The following is a description of a gene set: Genes in the cancer module 248. species: Homo sapiens Human Gene Set: MODULE_248, and this is the list of marker genes: SHB, USH2A, GRB10, TULP1, DGKE, HRH1, GUCY1A2, CASK, FGR, GNAT2, CRYGD, PTPN6, PTPN13, CRYM, PDLIM4 (NCBI Gene Id 8572), STAT4, SOCS3, RIN1, PRKCA, RASA3, ARAF, CNGA3, CXCL8, CXCL1, PITPNA, IMPG1, TULP2, HTRA1, ITK, LIN7A, PLCG1, SH2B2, APBA1, MPDZ, PHYH, RS1, MYOC, PRPH2, BCAR3, DLG3, EML2 (EMAP like 2), FBN1, LCK (NCBI Gene Id 95387), PTPN3, CYP1B1, GRK1, PDCL, ABL2, PRB4, TXK (TXK tyrosine kinase), CRYGA, PRKCQ, CXCR2, CRYAB, KRT12, RRH, SOCS1, PDE6B, BEST1, DGKA, PAX2, NPR2, BCR, PSEN2, PDE6A, PRKCG, STMN2, PRKD1, RCVRN, EML1, ARHGEF11, PTPN11, JAK1, WFS1, ADCY8, GRAP2, CYTIP, GUCY2D, S100A1, PRKCZ, CHN2, FES, ABLIM1, CRYBB2, FER, TYROBP, GRB7, PRKAR2A, RPE65, PLEK, FSCN2, PIK3C2G, CDH3, EFEMP1, GUCY2C, TGFBI, SH2D1A, DLG4, RCAN1, UNC13B, BFSP2, CNGA1, SLA, GRB14, STAT2, NOS1, BRAF, IL16, LUM, COL11A1, JAK3 (NCBI Gene Id 3718), SNTB2, PIK3R2, FKBP8, MPP1, ATXN7, NCF1C, RGS16, ARHGAP29, SHROOM2, GUCY2F, P2RY2, PRKCH, PDLIM3, ZBTB33, PAX6, VAV1, YES1, MERTK